The following is a description of a gene set: Human Gene Set: GOBP_RESPONSE_TO_GRAVITY Any process that results in a change in state or activity of a cell or an organism (in terms of movement, secretion, enzyme production, gene expression, etc.) as a result of a gravitational stimulus. studied in species Homo sapiens, and this is the list of marker genes: FOS, MSTN, STX1A, KRAS, GHR, NOX3, OTOP1, BGLAP